The following is a description of a gene set: species: Mus musculus Mouse Gene Set: REACTOME_CONDENSATION_OF_PROMETAPHASE_CHROMOSOMES Condensation of Prometaphase Chromosomes, and this is the list of marker genes: Smc2, Ncapd2, Smc4, Ncapg, Csnk2a1, Csnk2a2, Csnk2b, Ncaph